The following is a description of a gene set: Human Gene Set: KEGG_MEDICUS_REFERENCE_NRG_ERBB4_PI3K_SIGNALING_PATHWAY studied in species Homo sapiens Pathway Definition from KEGG: NRG -> ERBB4 -> PI3K -> PIP3 -> AKT NRG-ERBB4-PI3K signaling pathway. Pathway ID: N01163. Pathway type: Reference. Pathway class: nt06530 PI3K signaling., and this is the list of marker genes: PIK3CB, ERBB4, AKT2, AKT3, NRG3, PIK3CA, AKT1, PIK3CD, NRG2, NRG4, NRG1